The following is a description of a gene set: studied in species Homo sapiens Human Gene Set: GOBP_SENSORY_PERCEPTION_OF_SOUR_TASTE The series of events required to receive a sour taste stimulus, convert it to a molecular signal, and recognize and characterize the signal. This is a neurological process., and this is the list of marker genes: PKD1L3, ASIC1, ASIC3, SCNN1A, SCNN1D, PKD2L1, SCNN1B, ASIC2, SCNN1G